Given this list of marker genes POLR3K, NR0B1, NSMF, SUFU, PLXND1, FGFR1, CDH23, KIF21A, BAP1, BMP6, TBL2, RRAS2, KRAS, PROK2, MT-TW, NDN, PDGFB, FGF17, AKT1, TMEM270, OTX2, CCDC141, RRAS, TACR3, TAC3, PTPN11, HDAC8, HFE, DUSP6, LHB, HESX1, POLA1, GJB2, PTCH1, HS6ST1, RASA2, METTL27 (methyltransferase like 27), NCF1, POLG, MT-ND5, DCAF17, HJV, LAS1L, PRDM13, RBM28, SOS1, GTF2I, SEMA3A, FEZF1, NF2, SOX2 (SRY-box transcription factor 2), TRAF7, WT1, GPR101, TFR2, SOX10, TCF12, MT-TQ, NPAP1, EIF4H, LGR4, MT-TH, SNORD115-1, PWRN1, RAF1, FGF8, SPRY4, ELN, BUD23, GNRH1, TYMP, LIMK1, VPS37D, TP63, DMXL2, FKBP6, RFC2, SIX6, SRY, ANOS1, TUBB2B, LHX4, PIK3CA, TUBB3, MT-TF (mitochondrially encoded tRNA-Phe (UUU/C)), NHLH2, PCSK1, MT-TS2, MAP3K1, SOX3, DHX37, POLR3B (NCBI Gene Id 55703), DNAJC30, REV3L, GTF2IRD1, NDNF, SMO, LIG3 (DNA ligase 3), POU1F1, DNAL4, CHD7 (NCBI Gene Id 780907), NR5A1 (nuclear receptor subfamily 5 group A member 1), MT-CO3, LHX3, POLR3A (NCBI Gene Id 11128), SEMA3E, SPRED2, SMARCE1, KISS1R, KISS1, DCC, MT-TL1, RIT1, TERT (NCBI Gene Id 7015), CPE, COL25A1 (collagen type XXV alpha 1 chain), GLI2, STX1A, RAB3GAP1, NRAS, PHOX2A, CLIP2, CTNNB1, AXL, RAB3GAP2, RRM2B (NCBI Gene Id 50484), FOXA2 (forkhead box A2), ZFX, MT-ND4, RAD51, MAGEL2, HERC2, RNU4ATAC, PROP1, MT-ND6, IL17RD, DHH, BAZ1B, LZTR1 (leucine zipper like post translational regulator 1), CHD4, WDR11, HSD17B3, MEN1, MKRN3, BRAF, NTN1, SNORD116-1 (small nucleolar RNA, C/D box 116-1), GTF2IRD2, GNRHR, ANK1, MRAS, PWAR1, FSHB, SRA1 (steroid receptor RNA activator 1), RNF216, SIM1, SOS2, MT-ND1, PMM2, DMRT1, PROKR2, AIP, OCA2, SMCHD1, TUBA1A, MT-CO1, FLRT3, CBL, MT-CO2, PNPLA6, SMARCB1, SNRPN, BMP2, CBX2, CTDP1, SOX9, PTCH2, here is a description of the gene set: Human Gene Set: HP_HYPOGONADOTROPIC_HYPOGONADISM Hypogonadotropic hypogonadism species: Homo sapiens Hypogonadotropic hypogonadism is characterized by reduced function of the gonads (testes in males or ovaries in females) and results from the absence of the gonadal stimulating pituitary hormones: follicle stimulating hormone (FSH) and luteinizing hormone (LH).